Given this list of marker genes Nt5c3, H2-D1, Sp100, Zup1, Ifi209, Psme2 (proteasome (prosome, macropain) activator subunit 2 (PA28 beta)), Slfn5, Ifi47 (NCBI Gene Id 15953), Plac8, Stat1, Ifi27l2a, Hsh2d, Bst2, Cd47, Alyref, Ifit2, Oasl1, Ifi214, Isg15, Ifi208, Ddx24, Irf7, Smchd1, Mndal, Tor3a, Evi2a, Tap1, Irf9, Ranbp1, Ifi206, Shisa5, Psmb9, Phf11b, Psme1, Mrpl30, here is a description of the gene set: species: Mus musculus Mouse Gene Set: CUI_B_CELL_IL7_RESPONSE_UP Cytokines mediate cell-cell communication in the immune system and represent important therapeutic targets. A myriad of studies have highlighted their central role in immune function, yet we lack a global view of the cellular responses of each immune cell type to each cytokine. To address this gap, the authors created the Immune Dictionary, a compendium of single-cell transcriptomic profiles of more than 17 immune cell types in response to each of 86 cytokines (>1,400 cytokine-cell type combinations) in mouse lymph nodes in vivo. A cytokine-centric view of the dictionary revealed that most cytokines induce highly cell-type-specific responses. For example, the inflammatory cytokine interleukin-1β induces distinct gene programmes in almost every cell type. A cell-type-centric view of the dictionary identified more than 66 cytokine-driven cellular polarization states across immune cell types, including previously uncharacterized states such as an interleukin-18-induced polyfunctional natural killer cell state. from publication Cui A, Huang T, Li S, Ma A, Pérez JL, Sander C, Keskin DB, Wu CJ, Fraenkel E, Hacohen N (PMID 38057668) Genes positively differentially expressed in cell type: B cell upon treatment with cytokine: IL-7 in mouse lymph nodes in vivo.